Given this list of marker genes DGKZ, RWDD2A, CCDC88B, TIMM44, CCNE2, ACAT1, CENPF, ZNF771, CADM1, TMEM65, IRAK2, TERF2 (telomeric repeat binding factor 2), RAB39A, KANK2, SERPINB6, CMTM7, MOB2, GPR176, CRLF3, CCAR2, MADD, STAG1, SGSH, NFATC1, NDUFA1, NEURL1B (NCBI Gene Id 54492), CD300LF (NCBI Gene Id 146722), CDK2, SLC9A9, GCLM, MKNK2, MFSD13A, DGKD, GGA2, DMPK, CLEC4D, PFKM, BCL2L1, ARL2BP, HSPB6, TPCN1, MAP3K5, C4orf46, PTPN6, PIK3CG, GSTM4, MAN1C1, LRP8, HSDL1, FMNL3, ATP8B4, MINDY2, CEP55, SUOX (sulfite oxidase), CC2D1B, MMD, PDE1B, IQGAP2, NF2, PIR (pirin), KANSL1 (KAT8 regulatory NSL complex subunit 1), ZNRF1, RPP21, APBB3, C6orf62, NDRG1, PAPSS1, CERK, GLO1, SERHL2, RCBTB2, SLC30A5, INPP1, CD5L, LRCH2, MSRB2, CITED2, CERT1, DOCK5 (dedicator of cytokinesis 5), LPCAT2, AGO4, EPB41L2, XYLT2, MYH10, MKRN2, CPD, ECI2, PDZK1IP1, ERLIN1, M1AP, S100A11, RIF1, MACROD2, SHCBP1 (SHC binding and spindle associated 1), RNPS1, BHLHE40, TKT, HACD4, MTPN (NCBI Gene Id 94351), GALNT4, CAMP, NEU1, PAFAH1B3, NDUFB7, SNAP47, SPRY3, LANCL2, PPT1, ZFP36L2, TRAM1, MAGED1, PPP3CB, MSMO1, AKIP1, TRAPPC2L, TEDC1, KIF13B, CCDC25, PLXNA2, GNGT2, ALDH2, LTF, RNF213, PTTG1, LRP5, CGNL1, TBR1, TUBB2B, CNN2, DENND2C, PCNT, ZMAT5 (zinc finger matrin-type 5), ANKRD28, KIF3A, FASN, GPC4, CCN1, VPS16, SLC16A13, HDAC6, GLIS3, CPT1C, UGCG, CISD3, SLC16A10, SELENOW, FAM177A1, CDK16, CIP2A, YWHAH, TMEM184C, WASHC5, KCNK7, CTDSPL, PRSS16, CLN6, NAP1L2, ADGB, FNBP1, GAS2L3, PIGV, SLC16A7, TGFBR1, GLMP, EEIG2, WWP2, HSD17B7, ENTREP3 (endosomal transmembrane epsin interactor 3), LRRC45, PADI2, PDGFC (platelet derived growth factor C), SQLE, RNPEPL1 (NCBI Gene Id 58159), COL1A2, SLC9A5, USP22, GEN1, CPNE3, KIF23, GSN, FRAT2, CD33, MAGI3, FCGR2A, AKR1B15 (aldo-keto reductase family 1 member B15), ITGA6, CDK14, FCGR1A, RDX, GMFG, SSX2IP, RAB34, ALCAM, TNS3, OAS3, ITGB1BP1, DENND5A, ANAPC15, WAS, SASH1, here is a description of the gene set: from publication El Kasmi KC, Holst J, Coffre M, Mielke L, de Pauw A, Lhocine N, Smith AM, Rutschman R, Kaushal D, Shen Y, Suda T, Donnelly RP, Myers MG Jr, Alexander W, Vignali DA, Watowich SS, Ernst M, Hilton DJ, Murray PJ (PMID 17114459) species: Homo sapiens IL-10 or IL-6 stimulation of control 129xC57BL/6 murine bone marrow derived macrophages in the presence of LPS. We used microarrays to detail the global programme of gene expression changes in response to IL-6 or IL-10 stimulation in the presence of lipopolysaccharide. BMDMs were isolated from control, IL-6-/-, and IL-10-/- mice on a 129XBL/6 mixed background mice and differentiated in the presence of CSF-1 for 6-7 days. Cells were scraped and plated in 6 well plates at 2x10e6/well. Cells were washed with complete DMEM and rested for 1-2 hr before stimulation with combinations of IL-10 (10 ng/ml), IL-6 (2 ng/ml) or LPS (100 ng/ml) for 45 min or 180 mins. Complete biological replicates were performed. Genes up-regulated in bone marrow-derived macrophages at 45 min of stimulation by IL10 and LPS: wildtype versus IL10 knockout. Human Gene Set: GSE5589_WT_VS_IL10_KO_LPS_AND_IL10_STIM_MACROPHAGE_45MIN_UP